The following is a description of a gene set: Human Gene Set: HP_TYPE_1_MUSCLE_FIBER_ATROPHY species: Homo sapiens Type 1 muscle fiber atrophy Atrophy (wasting) affecting primary type 1 muscle fibers. This feature in general can only be observed on muscle biopsy., and this is the list of marker genes: SELENON, SYNE2, TPM3, HNRNPK, SPTBN4 (NCBI Gene Id 80322), ITGA7, LMNA, ACTA1, FHL1, EMD, TPM2, HACD1, ALG14, TMEM43, SYNE1, MAP3K20, RYR1, MYL2